The following is a description of a gene set: studied in species Homo sapiens Any process that results in a change in state or activity of a cell or an organism (in terms of movement, secretion, enzyme production, gene expression, etc.) as a result of a methylmercury stimulus. Human Gene Set: GOBP_RESPONSE_TO_METHYLMERCURY, and this is the list of marker genes: S100B, ALAD, FECH, CPOX, ANK2, ARSB